Given this list of marker genes MEG3, GLB1, MYH3, ASAH1, ALG12, FLNB, COMP, TNNI2, PAX3, ASXL1, DLK1, RTL1, RAC3, TNNT3 (NCBI Gene Id 8044), SIK3, NALCN, GALNS, KIDINS220, POR, TPM2, here is a description of the gene set: studied in species Homo sapiens Human Gene Set: HP_ULNAR_DEVIATION_OF_THE_WRIST Ulnar deviation of the wrist